The following is a description of a gene set: species: Mus musculus Mouse Gene Set: GOBP_NOTCH_SIGNALING_PATHWAY The series of molecular signals initiated by an extracellular ligand binding to the receptor Notch on the surface of a target cell, and ending with the regulation of a downstream cellular process, e.g. transcription., and this is the list of marker genes: Psen1, Nr0b2, Krt19, Hotairm1, Foxc1, Nle1, Dlx2, Gsx2, Ncstn, Adam17, Angpt4, Llgl2, Llgl1, Anxa4, Spen (spen family transcription repressor), Hp, Zbtb7a, Bmp7, Aph1b, Postn, Nepro, Arrb1, Tspan14, Ctbp1, Rfng, Hes1, Cdk6, Foxa1, Tgfb1, Gdf2, Gm11690, Sox2, Il17a, Fbxw7, Mettl3, Rcan2, Cntn1, Neurl1a, Cbfa2t2, Pdcd10, Hey1, Dll4, Jag2, Psen2, Snai1, Notch2, Galnt11, Mfng, Akt1s1, Aph1c, Rps19 (NCBI Gene Id 20085), Dll3, Epn1, Notch1, Robo2, Chac1, Tgfb2, Susd5, Nod2, Bmp2, Zmiz1, S1pr3, Tcim, Egfl7, App, Wnt1, Cebpa, Yjefn3, Jag1, Notch4, Ift88 (NCBI Gene Id 21821), Xirp1, Dlk1, Tmem100, Gdpd5, Mmp14, S2bpcox16, Mesp2, Pofut1, Dner, Synj2bp, Acvrl1, Slc35c2, Hey2, Mesp1, Trp63, Onecut1, Il2ra, Heyl, Psenen, Bcl6, Dtx3, Foxc2, Snai2, Bend6, Lfng, Neurl1b, Tm9sf5, Reck, Ripply1, Gas2, Agxt, Fgf10, Ovol2, Prag1, Grip2, Pgam2, Stat3, Cfap58, Dtx3l, Cc2d1b, Lrrk2, Dtx1, Gmds, Cntn6, Dll1, Hes7, Atoh1, Nrarp, Mib1, Dtx4, Kcna5, Rbpj, Foxa2, Perp, Mib2, Dlx1, Kctd10, Maml3, Cc2d1a, Nfkbia, Timp4, Etv2, Tspan15, Aak1, Notch3, Hnf1b, Slc35c1, Ttyh1, Itgb1bp1, Dtx2, Gata5, Ptp4a3, Bmp2k, Zfp423, Tgfbr2, Rian, Aph1a, Maml2, Cdkn1b, Neurod4, Mecp2, Tspan5, Tspear, Maml1, Arrdc1, Six1, Src (NCBI Gene Id 99351), Cdk3, Wdr12, Dicer1, Herc2, Sox9, Nrip2, Cfd, Ift74, Kit, Pln, Enho, Nr1h4, Il6st, Rbm15, Poglut1, Tbx2, Ift172, Dlk2, Ccn3, Ccdc85c, Ripply2, Gata2, Hhex, Epn2, Yap1, Nkap, Ascl1, Srebf2, Ccnc, Robo1, Hoxd3, Rita1 (NCBI Gene Id 97261), Hif1an, Fat4 (FAT atypical cadherin 4), Got1, Cd46, Cdh6, Hes5, Sel1l, Adam10, Ythdf2, Sorbs2